The following is a description of a gene set: Human Gene Set: BLANCO_MELO_COVID19_SARS_COV_2_POS_PATIENT_LUNG_TISSUE_UP Genes strongly up-regulated (log2(FC)>3.58, padj<0.05) in post mortem lung tissue from COVID-19 patients vs uninfected biopsy. Transcriptional profiling of post-mortem lung samples from COVID-19-positive patients compared with biopsied healthy lung tissue from uninfected individuals. from publication Blanco-Melo D, Nilsson-Payant BE, Liu WC, Uhl S, Hoagland D, Møller R, Jordan TX, Oishi K, Panis M, Sachs D, Wang TT, Schwartz RE, Lim JK, Albrecht RA, tenOever BR (PMID 32416070) species: Homo sapiens, and this is the list of marker genes: TRIM38, CLEC12B, ATP7B, MAP2K6 (NCBI Gene Id 5608), IL1RN, LILRA5, SERPINB9, TNFSF13B, PLAC8, CCDC140 (NCBI Gene Id 151278, CCDC140 long non-coding RNA), GAPT, BCL2L14 (BCL2 like 14), WAS, MX2, LINC01366, TMT1B, SLC26A8, IFITM3, TREML3P, IGSF6, GBP5, CCL7, APBB1IP, KCNJ2, CCL4, ALOX5AP, SRGN, SPI1 (Spi-1 proto-oncogene), IFI6, CA1, CDHR5, HERC5, GPR141, F5, SAMD9, CSTA, GTSF1, CYP4F3, ZDHHC19, PTK2B, SELL, S100P (NCBI Gene Id 6286), RGS18, ST20, OLR1, BCL2A1, APOBEC3A, NT5C3A, FPR1, RNASE2CP, DDX60L, KRT81, LY96, BASP1, HAMP, GPX2, H2BC21, IFIT1, CCL19, CHI3L1, VTRNA1-1, IFITM1, LAMP3, CLDN2, IFITM2, S100A12, EPSTI1, LINC02582, TPSB2, KCNJ2-AS1, ACOD1, PSTPIP2, IL27, OAS3, CACNA1A, CYP19A1, TNF, RNU11, RBP4, CCL8, P2RY13 (purinergic receptor P2Y13), RHOH, TNFSF14 (NCBI Gene Id 94566), SAMD9L, CLEC4A, PLEK, CALHM6, ANKRD22, S100A8, EVI2B, TYROBP, CDA, HBA1, ARSL, C6, AQP9, SHFL, LINC01093, C3AR1, FDCSP, CXCL10, SNORA12, ADGRE1, SIRPB1, LILRA6, FCER1G, ZBP1, STAP1, H2BC4, LCP1, OAS1, KLK10, HESX1, MXD1, RTP4, IL2RG, SP140, CHI3L2, TNFSF10, C19orf84, HLA-J, MIR3945HG, FFAR2, CLEC4E, EIF2AK2, KCNH7, DOK3, CSF3R, IFI44L, DAPP1, TARP, RNASE3 (NCBI Gene Id 6037), ARRB2, RIPOR2, PADI2, MX1, CCL11, OAS2, CPLX2, HSH2D, TMEM71, CLEC4D, IFIT3, RNU4ATAC, MMP8, CLC (NCBI Gene Id 1178), S100A11, LCP2, FYB1, TFEC, TASL, ISG15, TREM1, RNASE2 (NCBI Gene Id 6036), GPR84, DNAAF1, HS3ST3A1, TCN1, CEACAM3, CARD16, GCH1, CEACAM1, IFIT2, NBN, SYN1, MARCKS, CD37, CARD17P, CD53, CASP5, DOCK8-AS1, CCDC60, IL17C, CRISP3